The following is a description of a gene set: Human Gene Set: GOMF_MRNA_5_UTR_BINDING Binding to an mRNA molecule at its 5' untranslated region. studied in species Homo sapiens, and this is the list of marker genes: UTP23, SYNCRIP, RPS3A, LARP6, RSL1D1, LARP1, CCT5, RPL41, IGF2BP2, GNL3, RARA, IGF2BP1, SHMT1, RPL26, RPL5, IGF2BP3, FMR1, NCL, DDX3X, MYH10, RPS7, RPS14, DHX36 (NCBI Gene Id 96337), RPS13